Given this list of marker genes CSGALNACT2, CHST13, B3GALT6, CHST12, B3GAT3 (beta-1,3-glucuronyltransferase 3), CYTL1, B3GAT2, CHST7, IGF1, XYLT1, CHPF2, CHST11, PXYLP1, UGDH, SLC35B2, CHSY1, B3GAT1, CHPF, CSGALNACT1, XYLT2, CHST3, CHSY3, here is a description of the gene set: studied in species Homo sapiens Human Gene Set: GOBP_CHONDROITIN_SULFATE_PROTEOGLYCAN_BIOSYNTHETIC_PROCESS The chemical reactions and pathways resulting in the formation of chondroitin sulfate proteoglycans, which consist of a core protein linked to a chondroitin sulfate glycosaminoglycan. The chondroitin sulfate chain is composed of the repeating disaccharide unit beta-(1,4)-D-glucuronic acid-beta-(1,3)-N-acetyl-D-galactosamine, the latter of which can be O-sulfated. Chondroitin sulfate chains are covalently linked to serine/threonine residues (O-linked) of the core protein via a tetrasaccharide linker sequence (xylose-galactose-galactose-glucuronate).